The following is a description of a gene set: studied in species Homo sapiens Genes predicted to be targets of miRBase v22 microRNA hsa-let-7i-3p in miRDB v6.0 with MirTarget v4 prediction scores > 80 (high confidence targets). from publication Chen Y, Wang X (PMID 31504780) Human Gene Set: LET_7I_3P, and this is the list of marker genes: DICER1, CAMK2N1, ADHFE1, ATP2A2, DLX5